The following is a description of a gene set: from publication Graham SM, Vass JK, Holyoake TL, Graham GJ (PMID 17717066) Quiescent and dividing hemopoietic stem cells (HSC) display marked differences in their ability to move between the peripheral circulation and the bone marrow. Specifically, long-term engraftment potential predominantly resides in the quiescent HSC subfraction, and G-CSF mobilization results in the preferential accumulation of quiescent HSC in the periphery. In contrast, stem cells from chronic myeloid leukemia (CML) patients display a constitutive presence in the circulation. To understand the molecular basis for this, we have used microarray technology to analyze the transcriptional differences between dividing and quiescent, normal, and CML-derived CD34+ cells. Our data show a remarkable transcriptional similarity between normal and CML dividing cells, suggesting that the effects of BCR-ABL on the CD34+ cell transcriptome are more limited than previously thought. In addition, we show that quiescent CML cells are more similar to their dividing counterparts than quiescent normal cells are to theirs. We also show these transcriptional differences to be reflected in the altered proliferative activity of normal and CML CD34+ cells. Of the most interest is that the major class of genes that is more abundant in the quiescent cells compared with the dividing cells encodes members of the chemokine family. We propose a role for chemokines expressed by quiescent HSC in the orchestration of CD34+ cell mobilization. Disclosure of potential conflicts of interest is found at the end of this article. studied in species Homo sapiens Genes up-regulated in quiescent (G0) vs dividing (M) CD34+ cells isolated from peripheral blood of CML (chronic myeloid leukemia) patients. Human Gene Set: GRAHAM_CML_QUIESCENT_VS_CML_DIVIDING_UP, and this is the list of marker genes: CXCL2, CXCL8, CCL3, ANXA5, CXCL6, CXCL5, CCL19, EMP1, CXCL13, ZBTB10, IL1B, H2AC6, JUN, RGS1, CRHBP, SOD2, PCDH9, TRA2B, CXCL3, CCL20, TNFSF4, NFAT5, CXCL1, CCL8